The following is a description of a gene set: Human Gene Set: HP_INVOLUNTARY_VOCALIZATION Production of sound done without will or conscious control. Involuntary vocalizations include tics, stereotypies vocalizations as part of dystonia or chorea, continuous vocalizing behaviors such as groaning or grunting, pathological laughter and crying, and others. These vocalizations are not recognized as socially or culturally appropriate. Involuntary vocalization studied in species Homo sapiens, and this is the list of marker genes: SLC35C1, CHD8, SNAP25, SLC25A13, CKAP2L, ACTG1, ADAMTSL2, HCCS, XPR1, ADAMTS2, SLITRK1, MAPT, TREM2, UBAP2L, SLITRK2, RAI1, KDM5A, UBE2A, COL1A2, TCF4, SPTBN1, ITPR1, SQSTM1, NDUFB11, ATP6AP2, FGFR1, ACTB, TMEM106B, PSEN1, PUF60, GRN (granulin precursor), VPS13A, PLEC, PANK2, GNB1, VCP, CHMP2B, EHMT1, AMER1, HERC2, COL1A1, SMARCA2, FLCN, NAGS, GRIK2, ADNP, CYLD, KRAS, PDZD8, COX7B, HDC